The following is a description of a gene set: studied in species Homo sapiens Human Gene Set: LOPES_METHYLATED_IN_COLON_CANCER_DN Genes un-methylated aberrantly in HCT116 and Colo320 (colon cancer) cells. from publication Lopes EC, Valls E, Figueroa ME, Mazur A, Meng FG, Chiosis G, Laird PW, Schreiber-Agus N, Greally JM, Prokhortchouk E, Melnick A (PMID 18794111) Aberrant CpG methylation of tumor suppressor gene regulatory elements is associated with transcriptional silencing and contributes to malignant transformation of different tissues. It is presumed that methylated DNA sequences recruit repressor machinery to actively shutdown gene expression. The Kaiso protein is a transcriptional repressor expressed in human and murine colorectal tumors that can bind to methylated clusters of CpG dinucleotides. We show here that Kaiso represses methylated tumor suppressor genes and can bind in a methylation-dependent manner to the CDKN2A in human colon cancer cell lines. The contribution of Kaiso to epigenetic silencing was underlined by the fact that Kaiso depletion induced tumor suppressor gene expression without affecting DNA methylation levels. As a consequence, colon cancer cells became susceptible to cell cycle arrest and cell death mediated by chemotherapy. The data suggest that Kaiso is a methylation-dependent opportunistic oncogene that silences tumor suppressor genes when they become hypermethylated. Because Kaiso inactivation sensitized colon cancer cell lines to chemotherapy, it is possible that therapeutic targeting of Kaiso could improve the efficacy of current treatment regimens., and this is the list of marker genes: RPA3, EPM2AIP1 (EPM2A interacting protein 1), FHIT, MLH1, RUNX3, GSTP1, RBP1, ERCC1, SORBS3, MSH6, TFAP2A, DRD1, EBF3, TERT, THRB, CDKN2A, RPA2, PITX2, SMAD6, CDKN1C, NR3C1, GATA3, TSHR (thyroid stimulating hormone receptor), THBS1, TP73, BDNF, GRIN2B, APC